The following is a description of a gene set: from publication Gautam P, Hamashima K, Chen Y, Zeng Y, Makovoz B, Parikh BH, Lee HY, Lau KA, Su X, Wong RCB, Chan WK, Li H, Blenkinsop TA, Loh YH (PMID 34584087) Human Gene Set: GAUTAM_EYE_IRIS_CILIARY_BODY_MONOCYTES Occular cell types curated from Gautam and Hamashima et al. Multi-species single-cell transcriptomic analysis of ocular compartment regulons species: Homo sapiens, and this is the list of marker genes: ATG3, SCO2, MDM4, TMC6, SIGLEC10, BLNK (B cell linker), THBS1, CCDC88B, TMC8, NUDT1, CDC37, GNB4 (G protein subunit beta 4), TLR4, PSTPIP2, H2BC4 (H2B clustered histone 4), TSNAX, DUSP10, LLPH, GIMAP5, DPYD, VPS35, AREG, FLI1, PSTPIP1, PGP, SCN1B, CAP1, DENND4B, DDX39A, TUT7, ARL4C, H2BC8, GCH1, GPR155, DCTN4, TLR1, HPGDS, PAG1, ITSN2, GPRIN3, PTBP3, KYNU, ITGA4, NCF1, HOTAIRM1, NCKAP1L, S100A12, DOCK2, SESN1, THEMIS2, ABRACL, FGR, LIMD2, TGFBR1, SH2B3, FES, MT-ND4 (NCBI Gene Id 4538), CD48, LIPA, DDX3Y, PLAC8, ARID5A, RIPK2, ARHGAP24, SLC31A2, FNIP2, JAML, ITPR2, STK10, PRPF38B, C3, HDAC9, TBC1D2B (NCBI Gene Id 91449), FKBP4, INPP5D, GIMAP7, JAK3, MKNK1, IL16, NXF1, UCP2, ARHGAP30, EIF4EBP1, HLA-C, APOC2, SDCCAG8, CXCL1, RAB20, JDP2, DOCK11, SLC7A7, ALOX5, MIR142, C9orf72, BID, H2AC20, SIGLEC9, LILRB1, CEBPA, FRMD4A (FERM domain containing 4A), CLEC10A, IDH1, EBI3, RCBTB2, SNHG15, HLA-F, H2BC11, SERPINA1, H2AC8, CYSLTR1 (NCBI Gene Id 10800), HLA-A, IL2RA, CD4, SH3BGRL3, ZNF267, SPTLC2, ATP6V0C, PPARD, CD55, CLN8, CXCR4, ATF5, AAK1, STX11, SYK, SPRED1, UBALD2, SLFN11